Given this list of marker genes Lrrc55, Lrg1, Lrrc26 (leucine rich repeat containing 26), Lrrc52, Lrrc38, Akt1, here is a description of the gene set: species: Mus musculus Binds to and increases the activity of a potassium channel, resulting in its opening. Mouse Gene Set: GOMF_POTASSIUM_CHANNEL_ACTIVATOR_ACTIVITY